Given this list of marker genes SGO1, BOD1, NAA10, NAA50, BUB1, here is a description of the gene set: species: Homo sapiens The cell cycle process in which centromeres of sister chromatids are joined during mitosis. Human Gene Set: GOBP_MITOTIC_SISTER_CHROMATID_COHESION_CENTROMERIC